Given this list of marker genes MIR499A, MIR204, DKK1, MIR590, MEF2C, ARRB2, BMP4, SOX6, MYOCD, HDAC3, TGFB1, EFNB2, DLL1, MIR222, MIR1-1, BMP2, SMAD4, MIR200B, KAT2A, FZD7, FRS2, WNT3A, here is a description of the gene set: Any process that modulates the frequency, rate or extent of cardiac muscle cell differentiation. Human Gene Set: GOBP_REGULATION_OF_CARDIAC_MUSCLE_CELL_DIFFERENTIATION species: Homo sapiens